Given this list of marker genes VAMP8, ITGB2, ANXA3, STXBP2, VAMP7, VAMP2, BCR, STXBP3, ITGAM, SPI1, SYK, CD177, PRAM1, here is a description of the gene set: studied in species Homo sapiens The regulated exocytosis of secretory granules containing preformed mediators such as proteases, lipases, and inflammatory mediators by a neutrophil. Human Gene Set: GOBP_NEUTROPHIL_DEGRANULATION